Given this list of marker genes IFNG, IL4, NUPR1, SIRT3, IL10RB, IFNAR1, PRELID1, ENSG00000293600, IFNLR1, OAS1, OPN3, VCP, PARK7, PINK1, ISCU, here is a description of the gene set: Any process that activates or increases the frequency, rate or extent of cellular respiration. species: Homo sapiens Human Gene Set: GOBP_POSITIVE_REGULATION_OF_CELLULAR_RESPIRATION